The following is a description of a gene set: species: Mus musculus Any process that modulates the rate, frequency or extent of DNA strand elongation. DNA strand elongation is the DNA metabolic process in which an existing DNA strand is extended by activities including the addition of nucleotides to the 3' end of the strand. Mouse Gene Set: GOBP_REGULATION_OF_DNA_STRAND_ELONGATION, and this is the list of marker genes: Ino80c, Pot1a, Ruvbl2 (NCBI Gene Id 20174), Nucks1 (NCBI Gene Id 98415), Ino80b, Ino80, Actr8, Tfpt, Uchl5, Yy1 (YY1 transcription factor), Pot1b, Ino80d (NCBI Gene Id 329170), Actl6a, Nfrkb, Ino80e, Mcrs1, Ruvbl1, Actr5